Given this list of marker genes ERBB2 (erb-b2 receptor tyrosine kinase 2), BLNK, PRPS1 (phosphoribosyl pyrophosphate synthetase 1), MUC1, PVALB, EPOR, RAP1GAP, BAK1, ASB9, EFNA1, ENC1, H2AC18, SNCG, H2AC20, GPRC5A, SELENBP1 (NCBI Gene Id 8991), SLC16A5, CD24, CTSL, BCAS1, TM4SF1, ABCC5, COL4A5, ANXA3, ADORA2BP1, IL1R1, MXD4, MYO1B, LAMB1, CTSH, STC1, FOLH1, DBN1, SMAD3 (SMAD family member 3), CLU, NELL2, TGFB3, TTC9, PLK2 (NCBI Gene Id 10769), INSIG2, NDRG1, LITAF, BIK, ABCG1, ARHGAP4, GNS, TMEM131L, KLF6, KRT81, TARP, SLIT2, PPP1R3C, DDIT4, STXBP1, PXDN, GNE, LAMB2, MMD, RND3, IER3, SMPD1, TGFB2, MATN2, ERBB3, FMO5, INHBB, RBL2, DUSP4, MB, KRT7, ADIRF, DUSP1, LHFPL2, ARNT2, KYNU, BMP4 (NCBI Gene Id 652), INPP5J, ALDH4A1, here is a description of the gene set: from publication Frasor J, Stossi F, Danes JM, Komm B, Lyttle CR, Katzenellenbogen BS (PMID 14973112) Selective estrogen receptor modulators (SERMs) such as tamoxifen are effective in the treatment of many estrogen receptor-positive breast cancers and have also proven to be effective in the prevention of breast cancer in women at high risk for the disease. The comparative abilities of tamoxifen versus raloxifene in breast cancer prevention are currently being compared in the Study of Tamoxifen and Raloxifene trial. To better understand the actions of these compounds in breast cancer, we have examined their effects on the expression of approximately genes, using Affymetrix GeneChip microarrays, with quantitative PCR verification in many cases, categorizing their actions as agonist, antagonist, or partial agonist/antagonist. Analysis of gene stimulation and inhibition by the SERMs trans-hydroxytamoxifen (TOT) and raloxifene (Ral) or ICI 182,780 (ICI) and by estradiol (E2) in estrogen receptor-containing MCF-7 human breast cancer cells revealed that (a) TOT was the most E2-like of the three compounds, (b) all three compounds either partially or fully antagonized the action of E2 on most genes, with the order of antagonist activity being ICI > Ral > TOT, (c) TOT and Ral, but not ICI, displayed partial agonist/partial antagonist activity on a number of E2-regulated genes, (d) several stimulatory cell cycle-related genes were down-regulated exclusively by ICI, (e) the estrogen-like activity of Ral nearly always overlapped with that of TOT, indicating that Ral has little unique agonist activity different from that of TOT, and (f) some genes were specifically up-regulated by TOT but not Ral, ICI, or E2. Hence, gene expression profiling can discern fundamental differences among SERMs and provides insight into the distinct biologies of TOT, Ral, and ICI in breast cancer. Human Gene Set: FRASOR_RESPONSE_TO_ESTRADIOL_DN Genes down-regulated in MCF-7 cells (breast cancer) by estradiol (E2). species: Homo sapiens